The following is a description of a gene set: species: Mus musculus from publication Chen Y, Wang X (PMID 31504780) Genes predicted to be targets of miRBase v22 microRNA mmu_miR_5616_3p in miRDB v6.0 with MirTarget v4 prediction scores > 80 (high confidence targets). Mouse Gene Set: MIR_5616_3P, and this is the list of marker genes: Tbr1, Kctd7, Pcdhb19, B3gnt9 (UDP-GlcNAc:betaGal beta-1,3-N-acetylglucosaminyltransferase 9), Ccr3, Atxn10, Magi2, Ttc14, Khdrbs2, Ube2a, 1700025G04Rik, Sec22a, Nek4, Onecut2, Lonrf1, Kcnt2, Sorbs2, Rps6kb1, Mkln1, Arpp19, Fgf14, Wfdc8, Strbp, Rab28, Bmp2, Nrg4, Dcx, Was, Kdm5a, Khdrbs1, Cdk8, Taf3, Slf2, Exd1, 4930568D16Rik, Mtf2, Tut7, Igf1, Dlg5, Fmo6 (flavin containing monooxygenase 6), Ilf3, Tafa2